Given this list of marker genes Ubc, Cd7, Klf2, Junb, Tsc22d3, Uba52, Dusp1, Socs3, Cd28, Emb, here is a description of the gene set: Cytokines mediate cell-cell communication in the immune system and represent important therapeutic targets. A myriad of studies have highlighted their central role in immune function, yet we lack a global view of the cellular responses of each immune cell type to each cytokine. To address this gap, the authors created the Immune Dictionary, a compendium of single-cell transcriptomic profiles of more than 17 immune cell types in response to each of 86 cytokines (>1,400 cytokine-cell type combinations) in mouse lymph nodes in vivo. A cytokine-centric view of the dictionary revealed that most cytokines induce highly cell-type-specific responses. For example, the inflammatory cytokine interleukin-1β induces distinct gene programmes in almost every cell type. A cell-type-centric view of the dictionary identified more than 66 cytokine-driven cellular polarization states across immune cell types, including previously uncharacterized states such as an interleukin-18-induced polyfunctional natural killer cell state. Genes negatively differentially expressed in cell type: NK cell upon treatment with cytokine: TL1A in mouse lymph nodes in vivo. species: Mus musculus Mouse Gene Set: CUI_NK_CELL_TL1A_RESPONSE_DN from publication Cui A, Huang T, Li S, Ma A, Pérez JL, Sander C, Keskin DB, Wu CJ, Fraenkel E, Hacohen N (PMID 38057668)